Given this list of marker genes UBB, HES5, MAML2, FBXW7, RBX1, HDAC8, HDAC4, DLL1, KAT2A, EP300, UBA52, HEYL, HES1, PSEN1, HDAC10, HDAC2, TBL1X, PSENEN, ADAM10 (NCBI Gene Id 102), HDAC1, MYC, CREBBP, NOTCH1, TBL1XR1, HDAC5 (NCBI Gene Id 23342), RPS27A, RBPJ, HDAC6, UBC, NEURL1, NCSTN, HDAC7, HDAC3, APH1B, SNW1, NCOR2, SKP1, CDK8, PSEN2, HEY1, CCNC, MIB1, JAG2, DLL4, NEURL1B, HDAC9, MIB2, MAMLD1, MAML1, JAG1, NCOR1, MAML3, HDAC11, ADAM17 (ADAM metallopeptidase domain 17), CUL1, HEY2, KAT2B, APH1A, here is a description of the gene set: When found in cis, HD and PEST domain mutations act synergistically, increasing NOTCH1 transcriptional activity up to ~40-fold, compared with up to ~10-fold and up to ~2-fold increase with HD mutations alone and PEST domain mutations alone, respectively. HD domain mutations enable spontaneous, ligand-independent, proteolytic release of the NICD1 fragment, although mutants remain responsive to ligand binding, while PEST domain mutations prolong NICD1 half-life and transcriptional activity through interference with FBXW7 (FBW7)-mediated ubiquitination and degradation. NOTCH1 HD+PEST domain mutants annotated here are NOTCH1 L1600P;P2514Rfs*4, NOTCH1 L1600P;Q2440*, NOTCH1 L1600P;Q2395* and NOTCH1 L1574P;P2474Afs*4. species: Homo sapiens part of: Signaling by NOTCH1 HD+PEST Domain Mutants in Cancer Reactome Pathway: Constitutive Signaling by NOTCH1 HD+PEST Domain Mutants